Given this list of marker genes TXNDC12, CHAF1B, CEP83, PHF19, OLFM1, DDX51 (DEAD-box helicase 51), MRPL37, RPL5, EIF1AD, CISD3, BCS1L, DCLRE1A, NUP88, KLHL8, CCDC150, FANCE, LINC01619, SSX2IP, GPSM2, GPATCH4, HMGXB4, E2F8 (E2F transcription factor 8), TBC1D2B (TBC1 domain family member 2B), CDC26, FAM133B (family with sequence similarity 133 member B), ATIC, SERTAD4, PXMP2, PIK3CB, TOR3A, UBE3D, ZNF788P, COPRS, HSCB, MTHFD1, SNRNP25, TTI2, MCM6 (NCBI Gene Id 4175), AP4B1, THAP11, CLNS1A, UNG, NLE1, BRI3BP, ELAVL1, SMC5, LAMC3, POLQ, LHFPL1, SLC39A3, GNL3, NSRP1, NAA38 (N-alpha-acetyltransferase 38, NatC auxiliary subunit), ADAMTS3, SNORD114-3, PSRC1, NUP43, KIF18B, TET1, ANP32B, MCM4, HNRNPD, ZWILCH, GAR1, SLC29A1, AP4E1, DCAF4, RMI1, DDX23 (NCBI Gene Id 9416), TCF19, MRPL58, ST3GAL4, PPIG, FIGNL1, UTP14A, COX7B2, IPPK, FAM111B, GLI2, GLO1, MRM3, FGF14-AS2, PPARGC1B, NAA15, NTAQ1, SEPHS1, POP7, MFAP2, PSME3, ACAD9, MRTO4, CCDC136, KLHL32, NUP85, RIOK1, TICRR, EBNA1BP2, SUV39H1, RBMX2, BUD13, MUTYH, MCM2, MIS18A, LLPH, MATN1, EMC8, DKC1, ZNF318, SLC6A3, CHERP, RRM1, ACTR3B, CDC45, PRPF4, ASTE1, CCDC167, TMEM109, RGS10, TJAP1, NOC3L, UBE3C, MRPL9, ZNF398, TEDC2, SPAG5, CCDC59, EXOSC5, CARD9, CENPU, DDX19A, TUBG1, TARBP2, DTYMK, MYO19, CEP72 (NCBI Gene Id 55722), RSC1A1, CASP3, KTI12, ESS2, LTV1, SNRPA1, CTNNBL1, MRPS18B, NAF1, FEN1, CDCA4, POLD2, SCART1, CDCA8, RHNO1, NRF1, DHFR, DNTTIP2, NRM, TBC1D31 (TBC1 domain family member 31), CAMK4, HADH, TXNRD3, SIK2, CMTM7, ITGA9, DPY19L2P2, TENT4B, STK39, BLM, MFF-DT, ECE2, MYF6, NCAPG2, PSMB6, MALSU1, CABLES1, DHODH, FH, AURKB, PPIF, BRCA1, NR2F2, SLC37A4, CYGB, WDFY4, ELOVL1, DOK4, JADE1, HDAC1, TMEM115, G2E3, PTPN5, PRKAR2A, TLE1, PLD6, ZNF100, EIF3B, POLD3, SIX3, MRPS2, here is a description of the gene set: Human Gene Set: GSE21546_WT_VS_ELK1_KO_ANTI_CD3_STIM_DP_THYMOCYTES_DN Removal of the transcription factor SAP1a member of the Ternary Complex Factor (TCF) group of transcription factors which in conjunction with Serum Response Factor (SRF) has been shown to have a profound effect on positive selection in the thymus. When another TCF Elk1 is knocked out in mice there is no effect on positive selection unless it is on a Sap1a KO background where the phenotype is very severe. We have stimulated isolated double positive T cells (DPs) with anti-CD3 to mimic positive selection and compared basal and stimulated transcription across the four genotypes to discover the downstream targets of Sap1a involved in positive selection. from publication Costello P, Nicolas R, Willoughby J, Wasylyk B, Nordheim A, Treisman R (PMID 20554967) Genes down-regulated in double positive thymocytes stimulated by anti-CD3: wildtype versus ELK1 knockout. species: Homo sapiens